Given this list of marker genes TCF7L1, MYC, CDH1, CTNNB1, CCND1, TCF7, LEF1, TCF7L2, here is a description of the gene set: studied in species Homo sapiens Human Gene Set: KEGG_MEDICUS_VARIANT_CDH1_REDUCED_EXPRESSION_TO_BETA_CATENIN_SIGNALING_PATHWAY CDH1-reduced expression to beta-catenin signaling pathway. Pathway ID: N00061. Pathway type: Variant. Pathway class: nt06274 Thyroid cancer. Pathway Definition from KEGG: CDH1* // CTNNB1 -> TCF/LEF => (MYC,CCND1)